Given this list of marker genes MYZAP, GAA, CAPNS1, TTR, HADHB, LMNA, PSMB9, here is a description of the gene set: An elevated level of circulating N-terminal part of the prohormone of B-type natriuretic peptide (BNP). Human Gene Set: HP_INCREASED_CIRCULATING_NT_PROBNP_CONCENTRATION Increased circulating NT-proBNP concentration studied in species Homo sapiens